Given this list of marker genes Msx1, Notch1, Dll1, Hes1, Nkx6-3, Jag1, Nodal, here is a description of the gene set: Any process that prevents the activation of neuroepithelial cell differentiation. Neuroepithelial cell differentiation is the process in which epiblast cells acquire specialized features of neuroepithelial cells. Mouse Gene Set: GOBP_INHIBITION_OF_NEUROEPITHELIAL_CELL_DIFFERENTIATION species: Mus musculus